Given this list of marker genes GSKIP, KCNQ1, PRRC1, AKAP14, WASF1, AKAP9, PRKACA, C2orf88, AKAP8, PJA2, TDRD10, ACBD3, AKAP6, AKAP7, SPATC1L, PRKACG, ARFGEF1, WASF2, ARFGEF2, AKAP5, EZR, AKAP1, AKAP11, WASF3, AKAP8L, RYR2, here is a description of the gene set: Human Gene Set: GOMF_PROTEIN_KINASE_A_REGULATORY_SUBUNIT_BINDING studied in species Homo sapiens Binding to one or both of the regulatory subunits of protein kinase A.